Given this list of marker genes TRA2B, ADM, G3BP1, USP36, PSMB7, PLEK, NLE1, IRS2, AKAP1, SLC25A22, CACYBP, RCN1, UQCRFS1, MTCH2, CHST11, RBM34, SCARB1, UTP4, ST6GALNAC4 (NCBI Gene Id 27090), NUDCD3 (NudC domain containing 3), PPAT, ZC3H12C, EPOP, RRP9, SRM, SLC25A6, PDAP1, ENTPD6, ERAP1, XPOT, HPRT1, ATP1B3, ORC2, IFIT2, SNRPD1, TIMM8A, FOXRED2, SLC15A3, EIF5B, FABP5, HSPD1, IFIH1, LTA4H, ZC3H15, PRR3, CDK5R1, SLC25A32, EGR2, TLCD3A, NCS1, SEPTIN2, POP5, ERO1A, HOMER1, NOP9, HSPA9, CCDC141, MAFG, CDC34, IGF2R, ODC1, YWHAG, SRPRA, IFRD2, ALCAM, RCL1, MYO19, UTP18, RUVBL2, WDR18, SRSF6, ERH, RAVER1, WDR55, MAT2A, NRGN, BEX1, AIMP2, NFATC1, GRHL1 (grainyhead like transcription factor 1), ISYNA1, SRFBP1, UMPS, DDX18, HSP90AA1 (NCBI Gene Id 89272), OSGIN2, EIF4E (eukaryotic translation initiation factor 4E), DUSP4, PAFAH1B2, KTI12, PPP6C, RCC1L, MYO1E, B4GALT5, NUP205, MLLT1 (MLLT1 super elongation complex subunit), DNAJA2, CCDC137, ATXN7L3, PSMD8, WDR36, RBM15B, UBA6, EIF2B3, MAFF, BEX3, CHAMP1, ECE2, U2SURP, FASN (fatty acid synthase), SLC7A1, RENBP, RIOX1, IDE, PFKP, NFX1, EME2, SERPINB9, SMAD3, CIART, RGS16, SLC16A1, LZTFL1, RDH11, HILPDA, RRP8, RAP1B, EYA3, IL1R2, NUS1, ZNHIT6, PLEKHF2, CDV3, SNUPN, FOSL1, KLF16, RSL24D1, SPRYD7, RPS6KA2, AMZ1, LGALS3BP, FTSJ3, IARS1, EIF2S1, AGFG1, GLA, HSPH1, ALG3, MIOS, FNBP1, HSPE1, BTG3, C7orf50 (chromosome 7 open reading frame 50), MTRR, HEATR3, POLR3D, AHR, CCNB1IP1, PPIF, RCC1, SLC7A6, SNAI3, GMFB, SF3B4, SH2D2A, XCL1, CFLAR, ETF1, PDCD1LG2, SLC25A1, PLXND1 (NCBI Gene Id 23652), THOP1, GTPBP4, WDR77, VEGFC, SLC16A13, PRPS1, SELENOI, NAA50, FOXK2, CCT6A, EXOC2, CEP83, UTP6, LCK, ANKRD13B, WDR3, ARFRP1, TMEM184B, UQCRQ, AK7, URB2, PMP22, MFSD5 (NCBI Gene Id 84975), MYDGF, HCCS, MAK16, S1PR3, EPRS1, MAP2K3, here is a description of the gene set: Genes up-regulated in CD4 SMARTA memory T cells: Th1 versus follicular helper (Tfh). Human Gene Set: GSE43863_TH1_VS_TFH_MEMORY_CD4_TCELL_UP species: Homo sapiens from publication Hale JS, Youngblood B, Latner DR, Mohammed AU, Ye L, Akondy RS, Wu T, Iyer SS, Ahmed R (PMID 23583644) CD4 T follicular helper (Tfh) cells provide the required signals to B cells for germinal center reactions that are necessary for longlived antibody responses. However, it remains unclear whether there are CD4+ memory T cells committed to the Tfh lineage after antigen clearance. Using adoptive transfer of antigen-specific memory CD4+ subpopulations (based on CXCR5 and Ly6c expression)in the LCMV infection model, we found that there are distinct memory CD4+ T cell populations with commitment to the Tfh and Th1 lineages. Our conclusions are based on gene expression profiles, epigenetic studies and phenotypic and functional analysis. The gene expression profiles of virus-specific CD4 T cell subets at effector and memory stages is presented here.